The following is a description of a gene set: Pathway Definition from KEGG: Glc-1P -- UGP2 >> (GYG1/2+GYS1/2) >> GBE1 -> Glycogen Glycogen biosynthesis. Pathway ID: N00713. Pathway type: Reference. Pathway class: nt06017 Glycogen metabolism. studied in species Homo sapiens Human Gene Set: KEGG_MEDICUS_REFERENCE_GLYCOGEN_BIOSYNTHESIS, and this is the list of marker genes: GYG1, GBE1, UGP2 (NCBI Gene Id 7360), GYG2, GYS1, GYS2